Given this list of marker genes PDIA4, TPD52L1, DUSP6, WSB2, PERP, BAG2, CMAS, SERP1, RAB18, LXN, MYDGF, GOLPH3, IGF2R, ATP6V1A, CD9, DSG2, CRADD, FHDC1, NDST1, DAP, ITPR2, HAVCR1, here is a description of the gene set: from publication Landis MD, Seachrist DD, Montañez-Wiscovich ME, Danielpour D, Keri RA (PMID 15897883) Upregulation of HER2/ErbB2/Neu occurs in 15-30% of human breast cancers and correlates with poor prognosis. Identification of ErbB2/Neu transcriptional targets should facilitate development of novel therapeutic approaches. Development of breast cancer is a multistep process; thus, to identify the transcriptomes associated with different stages of progression of tumorigenesis, we compared expression profiles of mammary tumors and preneoplastic mammary tissue from MMTV-Neu transgenic mice to expression profiles of wild-type mammary glands using Affymetrix microarrays. We identified 324 candidate genes that were unique to ErbB2/Neu-induced tumors relative to normal mammary gland tissue from wild-type controls. Expression of a subset of these genes (82) was also changed in the preneoplastic mammary glands compared to wild-type controls, indicating that they may play a pivotal role during early events of ErbB2/Neu-initiated mammary tumorigenesis. Further analysis of the microarray data revealed that expression of several known transforming growth factor (TGF)-beta target genes was altered, suggesting that the TGF-beta signaling cascade is downregulated in ErbB2/Neu-induced tumors. Western blot analysis for TGF-beta-Receptor-I/ALK5 and immunohistochemistry for TGF-beta-Receptor-I/ALK5 and phosphorylated/activated Smad2 confirmed that the Smad-dependent TGF-beta signaling cascade was inactive in these tumors. Although absent in most of the tumor, phosphorylated Smad2 was present in the periphery of tumors. Interestingly, presence of phosphorylated/activated Smad2 correlated with expression of Activin-Receptor-IB/ALK4, suggesting that although Smad-dependent TGF-beta signaling is absent in ErbB2/Neu-induced tumors, Activin signaling may be active at the leading edge of these tumors. Cumulatively, these data indicate that the TGF-beta pathway is intrinsically suppressed in ErbB2/Neu tumors via a mechanism involving loss of TGF-beta-Receptor-I/ALK5. Up-regulated genes from the 65 most significantly changed (p<0.01) genes identified by two analytical methods in the mammary tumors induced by transgenic expression of ERBB2. studied in species Mus musculus Human Gene Set: LANDIS_ERBB2_BREAST_TUMORS_65_UP